Given this list of marker genes Shmt2, Gbp5, Brca1, Ccr8, Akap12, Stat5b, Il36a (NCBI Gene Id 54448), App, Elavl2, Il12b, Chuk, Oasl2, 9930111J21Rik1, Rps6ka5, Endog, Slc22a21, Gpd1, Grk2, Traip, Stxbp3, Mir365-1, Cacnb4, Oas1h, Vamp8, Ube2k, Mir331, Il5ra, Ctbp2, Tnf, Il17re, Ephb2, Ifit1 (interferon-induced protein with tetratricopeptide repeats 1), Mir96, Ifi204, Tnfrsf18, Sp100, Il13, Srsf7, Mir465b-1, Fabp4 (fatty acid binding protein 4, adipocyte), Mpc1, Cyp1b1, Hyal3, Hspa1b, Gipc1, Nkiras1, Mir324, Acsl1, Nol3, Prlr, Trim25, Ppp2cb, Eda, Mir302b, P4hb, Mir450-1, Mir100, Oas1f, Slc26a6, Mir500, Mir190b, Ifngr2, Stx11, Il36rn, Kat6b, Parp14, Ldlrap1, Sdad1, Tnfrsf21, Il15, Iigp1c, Krt8, Mapk7, Mir676, Il1a, Kcnj11, Fadd, Ifna6, Pxn, Prkca, Gsk3a, Comt, Cdc34b, Ikbke, Hnrnph1, Pcolce2, Dapk1, Xcl1, Syk, Mir152, Rnf185, Aanat, Mir130b, Spry4, Rffl, Src, Mir150, Mst1, Ifi211, Crkl, Tff2, Ptp4a3, Epha2, Epha4, Pirb, Gbp3, Cd44 (CD44 antigen), Slit3, Rc3h1, Fer, Rab7b, Eif4e2, Fasn, Kdm3a, Epsti1, Pira2, Ifna2, Ifitm6, Adamts12, Ikbip, Rps6kb1, Gm4841, Rif1, Ccl9 (C-C motif chemokine ligand 9), Atl2, Itih4, Stxbp2 (NCBI Gene Id 97457), Cdc42, Rraga, Cebpa, Mir18b, Npnt, Smpd3, Krt18, Sh2b3, Tut4, Kif5b, Usp27x, Erbin, Mir302d, Ybx1, Dnaja3, Ciita, Gsdme, Il6st, Crlf1, Gbp10, Xcr1, Erbb4, Icam1, Bspry, Abcg4, Klf6, Mir146, Mir216b, Cdk4, Acod1 (NCBI Gene Id 16365), Adam9, Mir380, Abcc2, Traf7, Mir362, Adipoq, Mir217, Col6a1, Ccl26, Hspd1, Cxcl9, Lrba, Traf2, Cactin, Pira13, Mrc1 (NCBI Gene Id 99352), Ifnar1, Tnfrsf11b, Cd274, Mir196a-1, Mrpl15, Irgm2, Mir24-2, Cyp27b1, Ybx3, Tmsb4x, Igf1r, Cfh (NCBI Gene Id 192290), Pparg, Stx4a, Il2rg, Adipor1, Was, Il4, Foxc1, Il7r, Mir29a, Inhbb, Tyro3, Mir485, Il1f10, Mir181a-2, Tlr2, Rps6ka4, Zfand6, Sharpin, Shpk, Foxo3, Sirt1, Grem2, Nrp2, Tank, Actg1, Vegfc, Rbm15, Pou4f1, Ackr4, Pax6, Cib1, Epor, Socs3, Shank3, Timp2, Mrgpra1, Eif4a2, Oas1c, Mir301b, Mir652, Yap1, Nfkbia, Card14, Mir695, Mir465c-1, Stx8, Xbp1, Ptgs2, Egfr, Numbl, Il9r, Cd40, Trim21, Entpd2, Slc27a1 (NCBI Gene Id 26457), Fasl, Tgtp2, Yy1, Tlr3, Arg1 (NCBI Gene Id 11846), Ifna15, Mir672, Mir467f, Asah1, H2-Q7, Rpl13a, Keap1, Hspa5, Eef1e1, Mir493, Mir9-1, Dhx9, Irf3, Gh, Mir135a-2, Capg, Ifna11, Otop1, F3, Zyx, Mir574, Col1a1, Gm13276, Nefh, Ifit2, Mir376a, Serpina3c, Mir205, Mir680-1, Mir204, Tbk1, Myo18a, Bbs2, Mir367 (NCBI Gene Id 723911), Smarca5, Mirlet7i, Mir467a-1, Timp4, Cxcl11, Pdx1, Duox1, Slc2a4, Ghr, Skil, Jagn1, Ccr9, Gapdh, Il22ra2 (NCBI Gene Id 359790), Mir325, Mapkapk2, Ifnz, Abcb1a, Ctsk, Bcl2l1, Mir27b, Csf2ra, Bcl2 (NCBI Gene Id 98734), Rab43, Cdc37, Gsk3b, Mir155, Rabgef1, Plvap, Hmgb1, Spi1, Ccr5, Sfrp1, Nsmaf (NCBI Gene Id 93775), Camp, Mir181c, Mir291a, Mapkapk3, Stat5a, Mir190a, Il11, Ifng, Cdc42ep2, Trim32 (tripartite motif-containing 32), Oas1d, Erbb2, Gm12185, Ereg, Cnot7, Hells, Mir297c (NCBI Gene Id 100124483), Calm4, Il3, Serpina3n, Il1rn (NCBI Gene Id 320052), Csf1r, Il1rapl2, Klf4, Mat2a, Adipor2, Trim2 (tripartite motif-containing 2), Cxcr5, Mir363, Mir467a-5, Ccl24, Npr2, Ccr10, Ecm1, Naip2, Slit2, Nr1d1, Irs2, Pdgfb, Calcoco2, Cxcr4, Myo1c, Samhd1, Klf11, Sycp3, Cx3cl1, Tyk2, Mir323, Il1rl2, Mul1, Mt3, Commd7, Ifi202b, Bad, Ikbkb, Setd2, Naip6, Il18rap, Tnip2, Lrat, Mcm2, Ptprf, St18, Sstr1, Ifne, Hcls1, Irak3, Ackr2, Evl, Eps8, Rack1, Mir137, Ppp1r9b, Mir34a, Gab1, Ubd, Nfkb1, Otulin, Adamts13, Mir19b-2, Serpina3h, Srsf3, Reg1, Adam10, Mir199a-1, Gapdhrt, Angpt1 (angiopoietin 1), Mir223, Zfp36l2, Pml, Insr, Ccl12, Ifngr1, Gata3, Wnt5a, Daxx, Dapk3, Timp1, Kdr, Tek, Casp6, Mir199a-2, Sele, Csnk2b, Il15ra, Ifi47, Fmr1, Hdac4, Mir103-1, Hax1, Tle4, Rab12, Irgm1, Spry2, Myb, Mir744, Serpina1c, Mir455, B3gnt2, Abcc9 (NCBI Gene Id 58900), Irak2, Gnpnat1 (glucosamine-phosphate N-acetyltransferase 1), Rad23b, Mir224, Kit, Nkiras2, Ccr7, Iigp1, Rplp0, Cxcl16, Mkrn1, Pira12, Naip1, Ptpn2, Nlrc5, Rnf125, Etv3, Mir449a (NCBI Gene Id 723868), Mir92-2, Notch1, Fgfr2, Il31ra, Tgtp1, Ddost, Ifitm1, Muc19, Ripk2, Fosl1, Rbmx, Ccl11, Efhc2, Gm13277, Gpr35, Cited1, Mapk14 (mitogen-activated protein kinase 14), Myog, Ccr4, Cxcr2, Actn4, Bag4, Mir106a, Tle5, Oas1e, Mir34c, Mir219a-1, Rps16, Ripor2 (NCBI Gene Id 76622), Gbp8, Star, Rpl3, Socs5, Epha7, Calm2, Mir449c, Ythdf3, Nos2, Cnot9 (CCR4-NOT transcription complex, subunit 9), Nfat5, Serpine1, Mir378a (NCBI Gene Id 723889), Nlrp6, Rnf31, Cxcr3, Mir210, Axl, Myod1, Mir670, Prkci, Ddx41 (DEAD box helicase 41), Dcstamp, Wbp1l, Mir145a, Gbp4 (NCBI Gene Id 17472), Il1b, Ch25h (NCBI Gene Id 12642), Col3a1, Csf1, Ext1, Mir467b, Csf3r, Fchsd1, Nup85, Ifnk, Sin3a, Xrcc5, Appl2, Hcn1, Robo1, Gm13272, Osm, Cd4, Mir200a, Pck1, Irf5, Tnfsf11, Ackr3, Epha8, Mir302c, Shfl (NCBI Gene Id 319278), Cxcl17, Avpr2, Ndufa13, Mir540, Capn2, Otx2, Mir503, Flt3, Il18r1 (interleukin 18 receptor 1), Gm5431, Pdia3, Epha1, Ctr9, Adar, Ankrd1, Ddr2, Mir7-1, Txndc17, Rora, Nme7, Isg15, Il23r, Mir29c, Vamp3, Ltk, Serpina1a, Met, Pde12, Crebrf, Mir369, Pcsk1, Akap6, Mefv, Casp8, Syncrip, Flicr, Ccr1l1, Prmt2, Alad, Cth, Mir222, Lrch1, Synj1, Mir127, Mir374b, Kif16b, Snx10, Mir125b-1 (microRNA 125b-1), Il9, Fkbp1a, Tnfsf18, Impdh2, Ephb4, Slco1b2, Rarg, Lepr, Gba1 (glucosylceramidase beta 1), Mir434, Trim41, Stat6, Mir706, Mir409, Mme, Slc25a5, Tirap, Il13ra1, Tradd, Mir467a-2, Foxf1, Csf2, Il2ra, Kat2a, Il20ra, Ntrk1, Spata2, Pim1, Mir431, Mir878, Dusp1, Ifnb1, Tuba1b, Serpina3m, Rbck1, Laptm5, Ifitm7, Dpysl3, Mir34b, Gbp6, Rnf113a1, Trim65, Usp25, Lsm14a, Birc2 (baculoviral IAP repeat-containing 2), Apoa1, Pou4f2, Abcd4, Ocln, Il22ra1, Ctnnb1, Mir7-2, Ptk2b (PTK2 protein tyrosine kinase 2 beta), Piga, Ifna1, Irak4, Rab11fip5, Irak1, Cldn1, Kdm5b, Sirpa, Ythdc2, Gpr146, Ptprt, Serpina3b, Has2, Map2k7, Mir881, Mir764, Pdgfra, Klf2, Mir219a-2, Mir19b-1, Tyms, Cd70, Tjp2, Kynu, Casp1, Sgms1, Trim56 (NCBI Gene Id 384309), Ggt1, Socs1, Atl3, Mga, Selp, Musk, Hsp90ab1, Jarid2, Pycard, Zfp42, Nanog, Map3k5, Epha5, Abca1, Lilra5, Il10ra, Slc11a1, Dtx1, Umod, Cdkn2b, Mir465c-2 (microRNA 465c-2), Mir489, Parp16, Eed, Serpina1b, Hdgf, Hk2 (NCBI Gene Id 15277), Mir103-2, Mir381, Alox15, Mir9-2, Mir125a, Mir467a-4, Gimap6 (GTPase, IMAP family member 6), Smim30 (NCBI Gene Id 97293), Tnfrsf1b, Eno1, Mir142, Ifna16, Mir143, Ccl3, Htra2, Map4k3, Fzd4 (NCBI Gene Id 14366), Gtf2h1, Ubtf, Crhbp, Calm3, Mapk11, Parp9, Trp53 (transformation related protein 53), Hyal2, Smad7, Cntnap2, Sox1, Nlrp12, Mir149, Ccl19, Ifnab, Gbp2 (guanylate binding protein 2), Mir185, Ildr1, Cxcr1, Ass1, Crnn, Mir339, Mkks, Ccl8, Cd24a (CD24a antigen), Stip1, Myd88, Il11ra3, Mir344, Ccr1, Tfrc, Palm3, Ccr2, Btk, Nr1h4, Ncl, Mir450-2, Ifit3, Trim44, Il17f, Fosl2, Slc1a1, Fnta, Mir181a-1, Tie1 (tyrosine kinase with immunoglobulin-like and EGF-like domains 1), Mir322, Ptprc, Hyal1, Hipk1, Gch1, Lims1, Mir92-1, Mir295, Ifna13, Mir301, Fntb, Gclc, Pou5f1, Rfx2, Rel, Serpina3i, Map3k7, Casr, Mir1934, Mir16-2, Plscr1, Gfpt2, Mavs, Ythdf2, Heatr9, Cxcl12, Rufy4, Pmm1, Gas6, Tnfsf13b, Smpd4, Fos, Aqp4, Ceacam1 (NCBI Gene Id 26365), Dicer1, Il12a, Gpr108, Cxcl1, Lrrc2, Ccl22, Mmp2, Ina, Irf1, Tnfrsf13c, Mir494, Ifitm3, Kras, Bst2 (bone marrow stromal cell antigen 2), Epha6, Ocstamp, Mir9-3, Aff3, Mir465b-2, Stoml1, Hpx, Ifna14, Myc, Lamp3 (NCBI Gene Id 239739), Entrep1, Tnfrsf1a, Ifih1, Ins1, Cd74 (NCBI Gene Id 16149), Lef1, Nfyb, Cntfr, Slc30a8, H2bc21, Ripor1, F2rl1, Atic, Cxcl13, Ifi213, Kmo, Rps3, Stxbp1, Zc3h12a, St3gal6, Spock2, Flnb, Il36g, Rnmt, Jak3, Igtp, Tmc8, Lcn10, Foxd3, Irf7, Egln3, Fgb (fibrinogen beta chain), Serpina3j, Vrk2, Birc7, Prkn, Ifna12, Mir344-2, Pla2g10, Ifna4, Stat4, Xiap, Fgf4, Mir182, Eif2ak2, Il1rl1, Ephb3, Usp29 (ubiquitin specific peptidase 29), Acp5, Phc1, Il27ra, Il13ra2, Aldh1a2, Mylk3, Usp10, Wdr35, Ephb1, Atp5f1b, Pcolce, Ret, Il11ra1, Il33, Jak2, Traf5, Mir29b-1, Mir384, Mir335, Relb, Ifitm2, Rab20, Hes1, C1qtnf4, Mapk13, Il10rb, Oas2, Il20rb, Serpina1e, Pafah1b1, Mir16-1 (NCBI Gene Id 387134), Ebi3, Postn, Cish, Dbn1, Rbmxl1, Adam17, Cd38, Mir206, Mir221, Mettl3, Mndal, Osmr, Tcirg1, Mir290a, Traf6, Gm36723, Sigirr, Mybl2, Cfl1, Mir200c, Mir101b, Mir467a-3, Mir125b-2, Ccl6, Thpo, Trex1, Gapdhrt2, Fgf23, Ifi208, Eda2r, Trpv1, Gper1 (G protein-coupled estrogen receptor 1), Fcer1g, Il11ra2, Ticam2, Mcl1, Mir302a, Inpp5k (inositol polyphosphate 5-phosphatase K), Epo, Prpf8, Mir294, Il34, P3r3urf, Sox9, Foxa2, Gclm, Mir345, Khsrp, Chi3l1, Gstt2, Edar, Stat3, Phb1, Cav1, Mir18, Mir135a-1, Mir467a-10, Stap1, Ccdc3, Mir21a, Tifa, Ccl2, Gfer, Mir183 (NCBI Gene Id 387178), Ntrk3, Hnrnpu, Ntrk2, Ro60, Dcst1, Klf5, Enah, Xaf1, Foxh1, Nfkbiz, Il1r1, Lox, Cacybp, Il7, Trim6, Mir370, Mir511, Mir20b, Gps2, Mir99a, Mir365-2, Mir671, Il1rap, Msc, Mir28a, Mcf2, Nmnat3, Arid5b (AT-rich interaction domain 5B), Zfp36l1, Mir544, Rnf138, Nkx3-1, Tslp, Mir342, Mpl, Mir340, Ros1, Saa3, Ifi203, Oasl1 (NCBI Gene Id 231655), Ccrl2, Lilra6, Ifi207, Mir298, Hif1a, Ifi205, Tnfrsf17, Rps2, Padi2, Adam23, Fn1, Mir1195, Mmp8, Ifi209, Pias3, Stat1, Casp4, Akt1, Gm13275, Upf1, Gbp2b, Kcnj8, Ripk1, Insrr, Naip5, Bbs4, Ackr1, Mir292, Ifnar2, Il10, Ifna7, Dock8, Otud4, Fgfr4, Traf3ip2, Cntf, Egr1, Mtf2, Trem2, Cx3cr1, Srsf1, Il2, Mir133a-2, Irs1, Cyld, Gpr75, Syngr1, Tollip, Epha10, Creb1, Mir296, Tpr, Traf1, Cd47, Bclaf1, Tnfrsf4, Mir133a-1, Alk, Ccr6, Mir680-2, Shmt1, Mir1896, Traf3, Ppp3cb, Wfdc21, Sox17, Ifna5, Zfp36, Srf, Pf4, Il17rb, Usp18, Pggt1b, Actr3, Mir27a, Ttll12, Ifi214, Taf9, Rara, Vamp4, Ccl25, Zc3h15, Csf3, Cd14, Wnk1, Mir293, Gapdh-ps15, Serpina1d, Mir687, Gfi1 (growth factor independent 1 transcription repressor), Mir690, Scgb1a1, Vim, Spp1, Oas1b, Il5, Birc3, Camk2a, Cd300lf, Tmem102, Mir300, Mapk3, Serpina3g, Snca, Smpd1, Prl, Mras, Mir532, Cdc34, Pde1b, Nup35, Mir211, Ddr1, Polr1f, Il17rc, Edn1 (NCBI Gene Id 13614), Ctrb1, Sell, Mir1a-1, Pdcd10, Plcb1, Nfe2l2, Mir467a-6, Smad4, Rela, Ikbkg, Slc12a2, Sting1, Cdc42ep4, Inhba, Lifr, Ptpn6, Mir193b, Fgfr3, Tuba1a (NCBI Gene Id 22142), Oas1a, Mir148a, Mir351, Dok1, Calm1, Aif1, Klf3, Ugcg, Zbp1, Serpina3f (NCBI Gene Id 257657), Gbp7, Il6ra, Ano1, Stk39, Fgfr1, Chchd4, Pdgfrb, Nkx6-1, Edn2, Il4ra, Gm11772, Socs2, Mir29b-2, Cxcl2, Mir467a-8, Pde2a, Adamts7, Mir741, Eprs1, Tlr4, Nol8, Mcemp1, Lyn, Ddias, Mir196a-2, Pnpt1 (polyribonucleotide nucleotidyltransferase 1), Hnmt, F830016B08Rik (RIKEN cDNA F830016B08 gene), Med1, Il21r, Csf2rb, Il36b, Crk, Pid1 (phosphotyrosine interaction domain containing 1), Trbv13-2, Mir216a, Ccl4, Ube2g2, Gbp9, Gm13271, Ilk, Mir665, Oas1g, Mir382, Cxcr6, Actr2, Mapk1, Dab2ip, Il1r2, Jak1, Slk (NCBI Gene Id 50513), Lsp1, Mir7b, Ifna9, Il17a (interleukin 17A), Serpina16, Il3ra, Epg5, Acbd7, Dcp1b, Txk, Flt4, Rnf113a2, Il12rb2, Vps26b, Ep300, Sphk1, Nr5a2, Calr, Aim2, Nfkb2, Gm13283, Pias4, Ccl1, Rigi, Traf3ip3, Prdm5, Rbm47, Socs4, Ccl21a, Il2rb, Bmi1, Mx2, Mir146b, Pik3r1, Oas3, Mertk, Stxbp4, Ifi206, Mynn, Il18, Fis1, Coro1a, Oxsr1, Il16, Mst1r, Cebpb, Fbxo21, Srm, Serpina3a, Mir470, Il6, Mir680-3, Cdip1, Mir467a-9, Map2k5, Mir679, Crlf2, Irf8, Mir410, Mir743b, Mir467a-7, Ror2 (NCBI Gene Id 26564), Il12rb1, Gsn, Il17rd, Gldc, Serpina3k, Mirlet7e, Lep, Timp3, Bcat2, Rhoa, Ifnlr1, Gigyf2, Slc22a5, Stat2, Cldn18, Tnfrsf11a, Nfil3, Csf2rb2, Duox2, Mir200b, Peli3, Pfkp, Flt1, Serpinf1, Sh2b2, Mir542, Mmp12, Cdk9, Ccl21b, Cpne1, Appl1, Mir433, Il17ra, Ccr3, Mir539, Cxcl10, Oxtr, Ccl7, Ubxn2a, Ccl5, Klf15, Epha3, Tex14, Gm12250, Ptgis, Alpl, Mir191 (microRNA 191), Mir592, Sbno2, Tcf7, Mir291b, here is a description of the gene set: Mouse Gene Set: GOBP_RESPONSE_TO_PEPTIDE Any process that results in a change in state or activity of a cell or an organism (in terms of movement, secretion, enzyme production, gene expression, etc.) as a result of a peptide stimulus. species: Mus musculus